The following is a description of a gene set: mouse primary BMDCs were stimulated with tlr ligands and gene expression changes were profiled on Affymetrix arrays from publication Amit I, Garber M, Chevrier N, Leite AP, Donner Y, Eisenhaure T, Guttman M, Grenier JK, Li W, Zuk O, Schubert LA, Birditt B, Shay T, Goren A, Zhang X, Smith Z, Deering R, McDonald RC, Cabili M, Bernstein BE, Rinn JL, Meissner A, Root DE, Hacohen N, Regev A (PMID 19729616) Genes down-regulated in comparison of dendritic cells (DC) stimulated with LPS (TLR4 agonist) at 12 h versus DC cells stimulated with poly(I:C) (TLR3 agonist) at 12 h. Human Gene Set: GSE17721_LPS_VS_POLYIC_12H_BMDC_DN studied in species Homo sapiens, and this is the list of marker genes: PLEKHO1, E2F8, MANBA, LPXN (NCBI Gene Id 9404), RPS14, BTG4, DPEP3, RASSF3, LAMA5, LAPTM5, VEGFA, SYNPR, HHEX, MAGI3, GCNT2, ANKRD27, QPCT, NT5C3A, ARF6, TNFRSF1A, DUSP11, LAT2, RPS10, GNAS-AS1, FUOM, CD9, NDRG4, RHOC, RNF34, PCP4, SDHAF2, TXNDC16, MGST2, ITGB7, USP33, TMEM176B, TLR3, TFG, SPMIP10, RPL28, LASP1, SESN2, MPP4, ANXA11, UAP1, RASA3, ECRG4, TANGO2, ASF1B, RPS25, FIG4, FLT1, RGS3 (regulator of G protein signaling 3), STOM, ZNF385A, MIS18A, WEE1, RHOU, RPL19, CLMP, ODF2L, SH3RF1, PHGDH, RABEP2, STK24, NDC80, DUT, LMNA, CARS1, REN, RFC2, CXCR4, SMIM14, STRBP, NAT1 (NCBI Gene Id 9), GTF2F1, CCNL2, METTL9, EPSTI1, IL15RA, HES6, CD68, BATF2, LRRC42, SLC37A2, SHARPIN, CCNL1, GNG11, SERPINB1, KLRK1, RARG, MAST1, WDPCP, PRMT2, POU2F1, CRCT1, SPDL1, GPSM2, TMUB2, CDYL, NFAM1, SLFN12L, PLA2G5, RNH1, STX3, SCN10A, MOG, CD300A, DLG3, RHO, EIF3H, ANGPT1, DHRS7, RSRP1, PNPO, POLR3GL, RRAD, VGLL4 (NCBI Gene Id 9686), IRF1, PCSK7, TLR9, ATP11B, PRPF38A, ARHGEF40, IFI30 (IFI30 lysosomal thiol reductase), TAP2, SEH1L, NEU1, MS4A1, SDCBP, THAP4, CPNE3, IRAG2, ASF1A, PSMA4, IRF5, NFIB, AHCYL1, HLA-DMA, TMLHE, SNX21, TM2D2, TIMP2, HNF1A, UCHL3, FLCN, EYA4, PXMP2, MAK, PKD2L2, PTCH1, PHLDB1, EMC8, FBXO21, SLC15A4, PLGRKT, HCFC1R1, TMEM128 (transmembrane protein 128), NAGA, RPS21 (NCBI Gene Id 6227), SAMHD1, PPP2R5B, EBPL, SAT1, ZFAND6, HS2ST1 (NCBI Gene Id 9653), VHL, SLC12A9, ADNP, SUN2, EGR4, TNFSF10, DNPEP, RASGRF1, APOD, LCOR, AP3B1, MXI1, NSMCE4A, CLEC6A, PRCP, NCK1, GALNT4, DOP1B, GPRC5B, APOBEC1, ITPR1, GPX2, TMEM234, SVBP, MBD4, RAB7A, SENP3, DDX4, SSBP1, ZFP91, VCAM1, SDC1, NFIL3 (NCBI Gene Id 4783), SMAD4